The following is a description of a gene set: part of: Innate Immune System studied in species Homo sapiens Reactome Pathway: Toll-like Receptor Cascades In human, ten members of the Toll-like receptor (TLR) family (TLR1-TLR10) have been identified (TLR11 has been found in mouse, but not in human). All TLRs have a similar Toll/IL-1 receptor (TIR) domain in their cytoplasmic region and an Ig-like domain in the extracellular region, where each is enriched with a varying number of leucine-rich repeats (LRRs). Each TLR can recognize specific microbial pathogen components. The binding pathogenic component to TLR initializes signaling pathways that lead to induction of Interferon alpha/beta and inflammatory cytokines. There are two main signaling pathways. The first is a MyD88-dependent pathway that is common to all TLRs, except TLR3; the second is a TRIF(TICAM1)-dependent pathway that is peculiar to TLR3 and TLR4. TLR4-mediated signaling pathway via TRIF requires adapter molecule TRAM (TRIF-related adapter molecule or TICAM2). TRAM is thought to bridge between the activated TLR4 complex and TRIF.(Takeda & Akira 2004; Akira 2003; Takeda & Akira 2005; Kawai 2005; Heine & Ulmer 2005). This pathway is organized as trafficking and processing of TLR, various TLR cascades (TLR10,TLR3,TLR5,TLR7/8,TLR9,TLR4,TLR2) and their regulation., and this is the list of marker genes: BIRC2, DUSP6, CTSS, SFTPA2, IRF7, MAP2K3, TRAF6, CTSV (NCBI Gene Id 1515), PELI3, MEF2A, EEA1, CUL1, LRRC14, TLR9, MAP2K4, RPS6KA2, MAPK1, ATF1, NFKBIA, UBC, CASP8, SOCS1, HMGB1, TRAF2, GSDMD, LGMN, PPP2R1A, S100B, RBSN, MAPK7, GSDME, PPP2R5D, CHUK, NKIRAS1, MAPK10, USP14, MAPKAPK3, porB, USP18, CD14, S100A1, BTRC, UBE2D2, LY86, IRF5, RPS6KA5, TIFA, IKBIP, S100A8, DNM2, PELI2, MAP3K1, DUSP7, PTPN4, OPTN, TLR5, NLRC5, S100A9, TBK1, RPS6KA3, fliC, IRAK3, RPS6KA1, APOB, TASL, PELI1, MAPK14, SAA1, UNC93B1, CNPY3, AGER, UBE2D3, N, IRAK1, TLR1, ALPK1, S100A12 (S100 calcium binding protein A12), TAB3, MAPK11, TP53, PPP2CA, DNM1, TLR4, BIRC3, TLR3, SFTPA1, CTSK, IKBKG, TAB2, IRAK4, ITGB2, RPS27A, MAP2K7, LY96, CREB1, NOD2, FBXW11, MYD88, ITGAM, FGB, TLR2, IRAK2, PIK3C3, TIRAP, BTK, NLRX1 (NLR family member X1), RELA, SLC15A4, PPP2R1B, mip, PLCG2, APP, TLR8, VRK3, LBP, MAPK8, MAPK9, MAP3K8, RIPK1, JUN, IRF3, MAPK3, TANK, UBA52, CD36, TNIP2, RIPK3, DUSP3, MAP3K7, SKP1, NFKBIB, RIPK2, CTSB, PIK3R4, TRAF3, MAP2K6, SFTPD, DNM3, MAPKAPK2, TLR6, PPP2CB, N4BP1, ATF2, TICAM1, UBE2D1, IKBKE, NKIRAS2, ECSIT, UBE2V1, SIGIRR, TICAM2, PTPN11, TLR10, MEF2C, FADD, TAB1, UBE2N, BPI, SARM1 (sterile alpha and TIR motif containing 1), ELK1, UBB, CD180, MAP2K1, FGG, NFKB1, NOD1, CTSL, DUSP4, TLR7, FGA, HSP90B1, FOS, IKBKB, NFKB2